The following is a description of a gene set: Human Gene Set: REACTOME_HDL_ASSEMBLY species: Homo sapiens HDL assembly, and this is the list of marker genes: APOA1, BMP1, PRKACB, ABCA1, PRKACG, PRKACA, A2M, ZDHHC8